Given this list of marker genes LTBP4, VASH1, MRPL23, KXD1, SLC6A11, RCE1, KAT6A, ATP5MG, RTCB, MSMB, SLC20A1, SLC16A3, POLR3C, PDCD4 (programmed cell death 4), LSM14A, SLC4A7, EGF, S100A10, ATXN1, RALB, PCDHB11, LGALS3BP, NDUFB8, PRSS53, ZNF217, SEPTIN11, DHCR24 (24-dehydrocholesterol reductase), PGM1, GPI, TNPO1, HEXB, SFTPB, SLC6A9 (NCBI Gene Id 6536), SLC18A2, PECAM1 (platelet and endothelial cell adhesion molecule 1), TSPAN4, ERF, PELP1, UROS, PPIP5K1, IRS1, GSK3B, PRCP, SFMBT1, ARMC8, H4C3, DIRAS3 (DIRAS family GTPase 3), RPL3, PPP1R10, PTGDS, FES, PNN, CAPN11, ABCB7, DNAJB12, CYB561, IPCEF1, CALM2, TFAP2C, RABL3, ELF3, SLC36A1, EXOSC8, ALDH1B1, IGHM, EMD, ABCE1, XPO7, CLSTN1, MECP2, MSLN, GUSBP3 (GUSB pseudogene 3), MCM7, NBR1, P4HA1, FNBP1L, RAB3GAP1, MRC1 (mannose receptor C-type 1), CDC16, DNAH7, PFKFB1, SNAPC2, TMC6, HTT, ZNF148, IGHD, GATD3, BMPR1A, LYL1, TSPAN31, KRT6A, RAB5C, FGFR2, S100A13, DPP6, VAMP3, TBL1X, HDAC5 (histone deacetylase 5), SP100, BMERB1, SPINT2 (serine peptidase inhibitor, Kunitz type 2), NIT1, TAF4B, ZBTB17, PSME4 (NCBI Gene Id 23198), GPR3, MAPK8, SH3BP1, EFNA2, THAP3, ITGB5, EPCAM, GNG12, NAA10, DUSP3, SYT17, H2AZ2, MBD3, AP3M2 (NCBI Gene Id 10947), CDK11A, ENSA, SLA, NDUFS1, IMMT, FSHR, ORC4, AP2B1, NELFB, MAPK8IP1, APRT, BTG2, MRPL28, TJP3, ASMTL, SLC2A5, PDIA4, DPY19L2P2, MARCO, CCSER2, THOP1, SPAG7, CTNNB1, FOXG1, CS, VGLL4, TSFM, INTS10, KCNJ1, SGTA, ACRV1, BRINP1, AP2S1, CYP2C18, NCBP1, DCUN1D4, STX12, PIAS2, DGKZ, RIMBP2, HLX, MAN2B1, BTN3A1, PPBPP2 (pro-platelet basic protein pseudogene 2), GAL, RASSF7, NUDT1, MISP, TBC1D1, GNPAT, SPEF1, EXTL3, GDI2, ERH, ATP6V1D, F7, CYP51A1, EML2, PCK1, GGA3, SMARCC1, RNASE4, LPO, PITPNM1, HNRNPF, ERCC3, GABPB1, CDH5, CPVL, ACAA1, IFNA16, SRSF6, PSMD1, RNF113A, CD70, IFT140, CDKL1, LDLRAD4, NUTF2, NSMAF, AURKA, here is a description of the gene set: Genes up-regulated in comparison of macrophages versus macrophages exposed to B. malayi (50 worms/well). Monocyte-derived dendritic cells (DC) and macrophages (MΦ) generated in vitro from the same individual blood donors were exposed to five different pathogens, and gene expression profiles were assessed by microarray analysis. Responses to Mycobacterium tuberculosis and to phylogenetically distinct protozoan (Leishmania major, L. donovani, Toxoplasma gondii) and helminth (Brugia malayi) parasites were examined, each of which produces chronic infections in humans yet vary considerably in the nature of the immune responses they trigger. Human Gene Set: GSE360_CTRL_VS_B_MALAYI_HIGH_DOSE_MAC_UP from publication Chaussabel D, Semnani RT, McDowell MA, Sacks D, Sher A, Nutman TB (PMID 12663451) studied in species Homo sapiens